Given this list of marker genes RACK1, PSMB4, CBLL1, PSMD7, CTSL, EPS15, RPS27A, JUP, PSMA5, PSMC3, PSMB2, SRC, PSMD3, MDM2 (MDM2 proto-oncogene), PSMD2, PSMA3, CTNND1, PSMC4, DNM2, MTBP, PSMD11, PSMB1, PSMD1, UBC, PSMC1 (NCBI Gene Id 5700), PSMA4, PSMA2, PSMA7, PSMB3, CTNNB1, PSMB6, UBA52, SEM1, PSMA6, UBB, PSMD14, BANP (BTG3 associated nuclear protein), PSMB7, CTNNA1, FYN, UCA1, PSMD12, PSMC6, CTSS, CDH1, PSMC2, PSMD8, PSMC5, PSMB5, PSMD13, ADRM1, PSMD6, CTSB, PSMA1, here is a description of the gene set: species: Homo sapiens part of: Regulation of CDH1 Function Reactome Pathway: Degradation of CDH1 <p>Early stages of epithelial-to-mesenchymal transition likely involve post-translational downregulation of CDH1, while later stages of EMT involve transcriptional silencing of CDH1.</p><p>Two E3 ubiquitin ligases have been reported to ubiquitinate CDH1 and promote its degradation. MDM2 (HDM2) was reported to mediate ubiquitin-dependent degradation of CDH1 by the proteasome, while CBLL1 (Hakai) was reported to mediated ubiquitin-dependent lysosomal degradation of CDH1.</p>